Given this list of marker genes Btg1, Tsc22d3, Ltb, Rsrp1, Emb, Fos, Gpx4 (glutathione peroxidase 4), Cd7, Rgs1, Zbtb20 (zinc finger and BTB domain containing 20), Il7r, Zfp36l2, Peli1, Fau, Il18r1, here is a description of the gene set: studied in species Mus musculus Genes negatively differentially expressed in cell type: NK cell upon treatment with cytokine: IL-7 in mouse lymph nodes in vivo. Mouse Gene Set: CUI_NK_CELL_IL7_RESPONSE_DN from publication Cui A, Huang T, Li S, Ma A, Pérez JL, Sander C, Keskin DB, Wu CJ, Fraenkel E, Hacohen N (PMID 38057668) Cytokines mediate cell-cell communication in the immune system and represent important therapeutic targets. A myriad of studies have highlighted their central role in immune function, yet we lack a global view of the cellular responses of each immune cell type to each cytokine. To address this gap, the authors created the Immune Dictionary, a compendium of single-cell transcriptomic profiles of more than 17 immune cell types in response to each of 86 cytokines (>1,400 cytokine-cell type combinations) in mouse lymph nodes in vivo. A cytokine-centric view of the dictionary revealed that most cytokines induce highly cell-type-specific responses. For example, the inflammatory cytokine interleukin-1β induces distinct gene programmes in almost every cell type. A cell-type-centric view of the dictionary identified more than 66 cytokine-driven cellular polarization states across immune cell types, including previously uncharacterized states such as an interleukin-18-induced polyfunctional natural killer cell state.